Given this list of marker genes CERS4, SPHK1, A3GALT2, B4GALNT1, DES, CERK, UGT8, CERS5, B3GNT5, CERS1, SGMS2, ASAH1, DGAT1, CERS2, A4GALT, CERS6, B4GALT1, UGCG, SPTLC1, SGMS1, KDSR, CERS3, here is a description of the gene set: species: Homo sapiens Human Gene Set: WP_SYNTHESIS_OF_CERAMIDES_AND_1DEOXYCERAMIDES Synthesis of ceramides and 1-deoxyceramides